The following is a description of a gene set: Any process that modulates the frequency, rate or extent of metallopeptidase activity. Mouse Gene Set: GOBP_REGULATION_OF_METALLOPEPTIDASE_ACTIVITY species: Mus musculus, and this is the list of marker genes: Cldn13, Timp2, Stat3, Svbp, Timp3, Rhbdf2, Timp1, Mbp, Cldn3, Reck, Antxr1, Cldn4, Ddrgk1